Given this list of marker genes Rasa1, Col6a1, Col4a2 (collagen, type IV, alpha 2), Pik3r2, Col9a1, Pdgfa, Stat5a, Col2a1, Thbs2, Col5a3, Thbs3, Plg, Thbs4 (NCBI Gene Id 21828), Col6a5, Spp1, Col6a6 (NCBI Gene Id 245026), Ptpn12, Hras, Grb2, Pik3cb, Crk, Bcar1, Stat5b, Pdgfrb, Pdgfb, Pdgfd, here is a description of the gene set: This event has been computationally inferred from an event that has been demonstrated in another species.<p>The inference is based on the homology mapping from PANTHER. Briefly, reactions for which all involved PhysicalEntities (in input, output and catalyst) have a mapped orthologue/paralogue (for complexes at least 75% of components must have a mapping) are inferred to the other species. part of: Signaling by Receptor Tyrosine Kinases Reactome Pathway: Signaling by PDGF electronically inferred by orthology from the curated human pathway species: Mus musculus